The following is a description of a gene set: studied in species Mus musculus BH3-only proteins associate with and inactivate anti-apoptotic BCL-2 members Mouse Gene Set: REACTOME_BH3_ONLY_PROTEINS_ASSOCIATE_WITH_AND_INACTIVATE_ANTI_APOPTOTIC_BCL_2_MEMBERS, and this is the list of marker genes: Bmf, Bcl2l11, Bad, Bcl2l1, Bcl2 (NCBI Gene Id 98734), Bid, Pmaip1